The following is a description of a gene set: Any process that decreases the rate, frequency or extent of keratinocyte proliferation. Keratinocyte proliferation is the multiplication or reproduction of keratinocytes, resulting in the expansion of a cell population. Human Gene Set: GOBP_NEGATIVE_REGULATION_OF_KERATINOCYTE_PROLIFERATION studied in species Homo sapiens, and this is the list of marker genes: KDF1, MED1, MIR125B1, KLF9, SFN, IRF6 (interferon regulatory factor 6), ZEB1, IFT172, SLURP1, CASK, INTU, EFNB2, VDR (vitamin D receptor), SNAI2, PTPRK, CD109, EPPK1, IFT52, PTCH1, IFT74, OVOL1, IFT80, FGFR2, IFT57